The following is a description of a gene set: The addition of a phosphate group on to the translation initiation factor eIF2alpha, as a result of endoplasmic reticulum stress. studied in species Mus musculus Mouse Gene Set: GOBP_EIF2ALPHA_PHOSPHORYLATION_IN_RESPONSE_TO_ENDOPLASMIC_RETICULUM_STRESS, and this is the list of marker genes: Eif2ak3, Tmed2, Dnajc3, Eif2ak4, Nck1